The following is a description of a gene set: The transcription factor IRF4 (interferon regulatory factor 4) is required during an immune response for lymphocyte activation and the generation of immunoglobulin-secreting plasma cells. Multiple myeloma, a malignancy of plasma cells, has a complex molecular aetiology with several subgroups defined by gene expression profiling and recurrent chromosomal translocations. Moreover, the malignant clone can sustain multiple oncogenic lesions, accumulating genetic damage as the disease progresses. Current therapies for myeloma can extend survival but are not curative. Hence, new therapeutic strategies are needed that target molecular pathways shared by all subtypes of myeloma. Here we show, using a loss-of-function, RNA-interference-based genetic screen, that IRF4 inhibition is toxic to myeloma cell lines, regardless of transforming oncogenic mechanism. Gene expression profiling and genome-wide chromatin immunoprecipitation analysis uncovered an extensive network of IRF4 target genes and identified MYC as a direct target of IRF4 in activated B cells and myeloma. Unexpectedly, IRF4 was itself a direct target of MYC transactivation, generating an autoregulatory circuit in myeloma cells. Although IRF4 is not genetically altered in most myelomas, they are nonetheless addicted to an aberrant IRF4 regulatory network that fuses the gene expression programmes of normal plasma cells and activated B cells. species: Homo sapiens IRF4 target genes up-regulated in primary myeloma vs. mature B lymphocytes. from publication Shaffer AL, Emre NC, Lamy L, Ngo VN, Wright G, Xiao W, Powell J, Dave S, Yu X, Zhao H, Zeng Y, Chen B, Epstein J, Staudt LM (PMID 18568025) Human Gene Set: SHAFFER_IRF4_TARGETS_IN_MYELOMA_VS_MATURE_B_LYMPHOCYTE, and this is the list of marker genes: SUB1, C11orf24, P4HA1, SLAMF7, CCNC, DUSP5, TNFAIP3, TNFRSF17, LDHA, KRAS, CD38, TUFT1, PABPC4, B3GNT2, ATP5F1D, PNP, FHL1, HSP90AA1, ATF4, BMP6, ACP1 (NCBI Gene Id 52), SORT1, AMPD1, UAP1, TXNDC5, UCK2, AHCY, SLC37A4, PDS5A, MPZL1, APOBEC3B, CYCS, SLC3A2, PAICS, GAA, SPATS2, MXI1, UBE2J1, F12, UBE2H, PPP1R2 (NCBI Gene Id 5504), PAM, HMBS, CCL3, LDLRAP1, NAMPT, HSPB1, DNAJC10, PIM2, SLC31A1, PDK1, ISG20, CYP51A1, PRDM1, DDIT3, BCL2L2, VDAC1, SUMO1, TIMP2, ADGRE5, TRAM1, BCKDHA, PDIA4, CASP3, CCPG1, NDRG1, ELL, PPP2R5C, CAV1, DNAJB9, ZFP36, HSP90B1, GFPT1, BSPRY, TM9SF4, GRSF1, FKBP11, SLC38A2, GNG7, YES1, UBE2B, CANX, MARS1, XPOT, ITGA4, YARS1, NR4A1, SEC62, HDAC5, SSR1, EIF2S2, PGK1, GARS1, PIP5K1B, MAN2A1, LDLR, ATF3, NFIL3, BMI1, CFLAR, MYC